The following is a description of a gene set: Human Gene Set: MODULE_464 species: Homo sapiens Oxidoreductases., and this is the list of marker genes: ALDH6A1, ALDH3B2, ALDH9A1, ALDH3A1, ALDH1A2, ALDH3B1, ALDH4A1, ALDH5A1, ALDH1A3, AOX1, ALDH3A2, ALDH7A1, BCKDHA, ALDH1A1